The following is a description of a gene set: studied in species Mus musculus Reactome Pathway: Bile acid and bile salt metabolism This event has been computationally inferred from an event that has been demonstrated in another species.<p>The inference is based on the homology mapping from PANTHER. Briefly, reactions for which all involved PhysicalEntities (in input, output and catalyst) have a mapped orthologue/paralogue (for complexes at least 75% of components must have a mapping) are inferred to the other species. electronically inferred by orthology from the curated human pathway part of: Metabolism of steroids, and this is the list of marker genes: Osbpl6, Akr1c6, Slc27a5, Ch25h, Ncoa1, Slc10a1, Akr1c21, Abcb11, Osbpl1a, Cyp8b1, Cyp46a1, Baat, Akr1c13, Amacr, Akr1c20, Osbpl2, Akr1c14, Slco1a4, Slc27a2, Osbp, Acox2, Cyp39a1, Slc51b, Fabp6, Abcc3, Acot8, Nr1h4, Slc10a2, Akr1d1, Akr1c18, Alb, Cyp7a1, Hsd17b4 (NCBI Gene Id 15488), Osbpl7